Given this list of marker genes CORIN, ICOSLG, SLC34A1, FZD9, CRIPTO, KCNQ3, TSHR, MDGA1, RAMP3, SEMA7A, CD47, CRLF2, SLC46A1, CSF1R, ASTN1, HHLA2, HCN1, FSHR, NCAM1, CCR9, SCNN1G, CCR3, PECAM1, CNTN2, TRGV4, CXCR3, DSCAML1, CD86, SLC1A1 (NCBI Gene Id 6505), PSG5, PDIA4 (protein disulfide isomerase family A member 4), ERMAP, IL1RAP, TRGC1, ELANE, ADAM32, SEMA6D, NLGN4X, IL15RA, CXCL12, AXL, ANTXR1, GHRHR, SFRP1 (NCBI Gene Id 6422), SLC46A2, ISLR2 (immunoglobulin superfamily containing leucine rich repeat 2), ACVRL1, FCN1 (ficolin 1), WIF1, CLEC17A, HRG, CRIPTO3, FOLR3 (NCBI Gene Id 2352), SLAMF6 (NCBI Gene Id 114836), PRND, CD83, CAV3, SCNN1A, IRAK1, L1CAM, KCNE2, CLEC1B, PHB1, CFC1B, AZGP1, ADGRE1, TMIGD1, PDCD1LG2, MRC1, SIGIRR, ITGA8, EPHA4, MUC17 (mucin 17, cell surface associated), ITGB1, ADAM15, SLC9A3, CTSK, IL1RAPL2, AIMP1, ADAM17, UPK1A, CEACAM7, GPC4, ANTXRL, TLR2, MPL, CD207, SLITRK6, ADAM30, CD79B, FCRLA, TNF, NOTCH2, KLRK1, CAPN5 (NCBI Gene Id 7445), CST8, CD248, RTP1 (NCBI Gene Id 132112), BTNL10P (butyrophilin like 10, pseudogene), CD244, ADAM28 (ADAM metallopeptidase domain 28), HILPDA, ADGRA2, ATP1A2, PTPRJ, SERPINA5 (serpin family A member 5), FCGR2C, CD24, HAVCR2, ENTPD6, UNC5C, CAPN2, FZD5, ROBO4, TNFRSF1A, GP2, ITGA1, CD44, ITGA2, IL11RA, CLEC4E, MME, CLEC4A, GFRA4 (NCBI Gene Id 64096), ENG, FCRLB, CD163L1, MBL2, KLRC1, CXCR2, CALR, FZD6, CD14, CD80, TNFRSF4, ICAM1, PACC1 (proton activated chloride channel 1), TREML4, ITGAE, ACVR1B, BTN3A1, IL13RA2, MR1, CD200, IL12RB2, IL4R, TF (transferrin), IL1RL1, HLA-H, PROM1, HAVCR1, P2RX1, HLA-DRB1, CD109, TPBG, NOTCH4, ROBO1, LRFN2, CCR1, ATP5F1A, BTN2A2, RTP2, MYH9, TNFRSF11A, CLEC5A, BTN3A2 (butyrophilin subfamily 3 member A2), FCGR2A, GFRA2, BMP2 (NCBI Gene Id 650), HLA-G, CLDND1, CD63, SULF1, TSPAN33, ENOX2, LAMP3, GP6, CD1C, ANXA5 (annexin A5), PLET1, SCARA5, GFRA3, LCT, MXRA8, IL9R, S100A10, LRRTM1 (NCBI Gene Id 347730), AQP4, VEGFA, FGFR3, EGFL8 (NCBI Gene Id 80864), EGFL7, IL1R2, LMAN2, S1PR1 (NCBI Gene Id 51546), INTU, EMP2, ANTXR2, CLMP, ATP5PO, CEACAM4, CD1E, HBEGF (heparin binding EGF like growth factor), CD8B, TFRC, SPN, LRFN1, LAMP1, F10, IL2RB, CD27, ZPLD1, TRPV2, CXCR4, PRNP, THY1, GPC6, HSP90AA1, FCGR1BP, HM13, FAM234A, SELE, ASIC1, WNT1, CD1B, UMODL1, ITGA11, SLC22A11, WNT5B, ROR1, LRP8, SLC7A11, TRGV9, IZUMO1R, MPZL1, BSN, BTNL9, LAG3, SLAMF1, PTPRK, MAP3K5, CXCR6, PLVAP, TNFRSF10B, CLEC12B, LBP, ADAM7, PSG11, GPRC5B, CYP2W1, ASGR1, PTPRT, AMBP, SLC9A1, ACVR2A, HYAL2, PROCR, ATP5F1B, SLC6A2, KRT4, DMD, GPIHBP1, CD74, TMEM8B, FCRL1, SRPX2 (sushi repeat containing protein X-linked 2), CLEC7A, STRC, TGFA, HSPA5, ALCAM, ITGBL1, CCR8, FZD3, IGSF5 (NCBI Gene Id 54046), TMEM102, LRRC32, LEPR, CLIC4, CD274, IL18R1, CD209, TYROBP, KCNA5, LDLR, INSR, NTRK1, FGA, GRIA1, NEO1, AMELX, TSPAN15, ATP6AP2, CSF3R, FGFBP1, MUC16, ABCG2, CD84, HLA-DPB1, SELL, LY6D, DUOX1, ADAM9, RAET1G, ECE1, SLC2A4, TPO, BMPR2, FURIN, CLEC9A, LTF, ITGA5, IL12RB1, GJD3, ITGAD, ENO1, GRIN2A, TGFBR3, IL17RC, NOTCH1, TREML2, OIT3, IL17A, KLRC3, CXCL9, CD19, LY6G5B, CLEC10A, GPR37, PXDN, SULF2, SLC32A1, OTOA, RAMP1, PPFIA2, CUBN, TMX3, FOLR1, VASN, DPP4, CSPG4, FZD10, ENPEP, CD3G, CASR, RALA, ABCG1, MSLNL, HMGB1, ITGB2, SLAMF7, TEK, CTSB, ADTRP, RS1, IL27, LY6G6D, FOLR2, RTN2, AOC3, MRGPRX1, ROBO2, IL7R, KCNC1, COLEC11, SLC4A3, C3, PSG2, HHIP, SCUBE3, ST14, PROM2, LRPAP1, CEACAM8, KLRB1 (NCBI Gene Id 3820), PHB2, MCAM, SLC39A6, HLA-DMA, ITGB3, ADGRV1, IGF2R, EPO, CTSZ (NCBI Gene Id 1522), ITGA6, LY6G6C, WNT4, LRP4, ADAM29, RC3H2, KISS1R (KISS1 receptor), NDP, LAYN, RTN4RL1, SORL1, CLEC4G, ACKR3, GPRC6A, P2RY12, ADAMTS15, CLEC4M (NCBI Gene Id 10332), IL18RAP, CD8B2 (NCBI Gene Id 927), ERP29, HMMR, TRGV3, IL2RG, CLEC6A, ITGB4, CEACAM6, TECTB, FLT3LG, ADGRG2, FCRL5, IL23R, TLR3, TNFSF4, BMPR1A, FCRL3, GRIN2B, CD6, PDGFB, CD4, KLRD1, GHR, SIRPB1, LRFN5, LIFR, PDGFC, ACE, C17orf99, FCGR3A, HPN, NRDC, ANXA9, MYH10, MS4A2, PICALM, FCGR3B, CD200R1L, CD1D, ADAM10, ADGRA3 (NCBI Gene Id 166647), EPHA2, PKD1, TAS2R16, BTNL3, CDH17, TNFRSF10A, ITGAL, TNS1, ITGAX, ITGA3, NLGN1, GREM1, ADGRF5, MS4A1, CLEC4F, KCNN2, FCER2, LRFN4, PPFIA4, ATP5IF1, BSPH1, SLC7A5, CD36, KCNH2, CCR7, ABCC2, COLEC10, CD34, ADCYAP1R1 (NCBI Gene Id 117), EPHB2, BTN2A3P, LYZL6, PCSK9, HFE, GRIA2 (glutamate ionotropic receptor AMPA type subunit 2), TMC1, FGF10, ABCA1, HSPA2 (heat shock protein family A (Hsp70) member 2), CNTNAP2, SEMA6C, SPTB, TSPAN8, ULBP1, LIPG, GPC2, FGG, TNFRSF10D, SCNN1B, SLAMF8, GPC3, ADAM8, ENPP3, BACE1, MMP16, FCRL4, FUT4, ANK3, ABCA7, IL3RA, ITGA9, KDR, PLXNB3, FCN2, HYAL4, LRP2, ANXA1, TCN2, MICB, TNFRSF18, TGFB1, FZD1, TSPAN14, RTBDN, CD163, WNT6, IL2RA, AQP11, ADIPOQ, SHH, APMAP, LY6G5C, CD99L2, IQGAP2 (NCBI Gene Id 10788), FCRL2, USP14, HSP90AB1, P2RY1, FCER1G, AJAP1, SDC4, CLPTM1, RAET1L, WNT7A, CLEC2D, CHRNB2, CCR10, RSPO2, CD276, CX3CL1, TRPV4 (NCBI Gene Id 8098), PLAUR (NCBI Gene Id 5329), BTNL2, LY75, ENTPD1, KCNB1, PDGFRA, CD40, EPHA5, GPC5, ADAMTS13, BST2, FGF8, NOD2, SPARC, CX3CR1, CD55, ACKR4, CFTR, UMOD, CD22, SORT1 (sortilin 1), MBP, PKD2L1, IL21R, SLC38A1, TMPRSS11F, TSPEAR, CD93, FOLH1, NTSR1, CLEC4C, CLU, FLOT1, IL13, RGMA, FGFR2 (NCBI Gene Id 2263), LMO7, FCGR1A, MICA, TRGV1, CD1A (NCBI Gene Id 909), TRGV2, TGFBR2, BGN, WNT3A, F2R, PKHD1, PDGFA, ITGAV, MSLN, ENO2, SCARB1, CSPG5, CLEC14A, ABCB1, AREG, BTN1A1, CSF2RB, PLXNB2, EGFR, FAP, ENPP1, LPAR1, FAS, STAB2, TYRO3, HLA-E, GPC1, BTN3A3, HLA-B, SDC1, LILRA5, IL1R1, TACR1, CCRL2, LPL, SCUBE2, CHRNA1, CLSTN1, CDH5, RAMP2, CD226, DIP2A, IRAK4, CD200R1, TRPM8, ITGA7, SLIT2, SLC1A3, TNFRSF14, CLEC4D, AGER, IDE, CEACAM5, B4GALT1, IL5RA, CD2, VTCN1, CD5, KRT10, PCSK6, GFRA1, HLA-DPA1, F2, TNN, PVR, IGSF3, ULBP3, VAMP4, HLA-C, CD9, STX4, LRRC8A, HJV, VAMP5, ADAMTS9, CCR2, ADAM20 (ADAM metallopeptidase domain 20), NCR2, TRGV5, PLAT, CPM, SLITRK3 (NCBI Gene Id 22865), CD58, UNC5D, SLC4A4, HTR3B (5-hydroxytryptamine receptor 3B), ART1, MYD88, ANPEP, EPOR, PTGFRN, BTN2A1, ANOS1, CD79A, IL12B, PKD1L3, CA4, DAG1 (NCBI Gene Id 1605), ELSPBP1, ENOX1, CCR4, NPTN, HLA-F, TRPC4, ADAM2 (ADAM metallopeptidase domain 2), CSF2RA, SLC6A3, APP, FCRL6, SARM1, GLRA1, DSG2, GSR, VCAM1, CUZD1, TFPI, TNFRSF10C, HCST, VWDE, SERPINF2, TLN1, SCUBE1, DNAI2, CLCN3, ULBP2, TSPAN32, SIRPA, IL31RA (interleukin 31 receptor A), PLA2R1, SDC3, NECTIN2, NRCAM, TRGV10, HLA-DRA, APOH, TIGIT, LILRB4, MIF, CDH2, SELP, CXCR5, APOA4, EFNA5, NRXN1, PRLR, LRP6, ITGAM, FCER1A (NCBI Gene Id 2205), SRPX (NCBI Gene Id 8406), IL6R, ITGB8, ABCC4, ACKR2, CEACAM3, PSEN1, GABRB3, HSPD1, PLAU, KCNA1, TIRAP, CEACAM20, DCC, RTN4RL2, KLRC2, STRCP1, IGHM, CEACAM21, F3, FCN3, IL17RB, CLSTN2, CXCL10, DCBLD2, SPA17, ACHE, FASLG, CRLF1, SMIM1, NOTCH3, ITGB7, TNFRSF13C, PTPRC, MELTF, CD59, CD69, VAMP3, IL1RL2, MYO18A, SEPTIN2 (septin 2), IL13RA1 (interleukin 13 receptor subunit alpha 1), PDCD1, CD5L, RER1, KLRC4-KLRK1, SLAMF9, B2M, TNFRSF12A, LGALS3, GFRAL, NGFR, KCNH5, CCR5, CD38, PDIA3, H1-1, PLA2G1B, EPPIN, IGSF21, LILRB1, CEACAM1, DCSTAMP, TFR2, CLSTN3, CD40LG, LRRC24, SCN5A (NCBI Gene Id 652341), CD46, CLEC2A, MET, ANGPTL3, CXCR1, EFNB1, ARSB, ALPP, ITGA4, CD8A, ASGR2, HNRNPU (heterogeneous nuclear ribonucleoprotein U), SLC1A4, JAM2, GRIN1, CD28, CDH13, MILR1, BTNL8, AMOT, GP1BA, BMP10, OSMR, ERP44, TREML1, NRROS, SDC2, ADGRG6, SLC3A2, NLGN2, TNFSF18, ADA, SLC6A1, FERMT2, FGB, CD33 (NCBI Gene Id 945), TLR4, TLR8, KCNK2, DUOX2, CD151, NLGN3, CD3E, CACNG4, ABCB11, IL6ST, CHRNA4, C1QBP, FGF22, MOG, ANXA2, P4HB, CRYAB, WNT5A, MST1R, LY9 (NCBI Gene Id 95630), TGFBR1, ADAM21, BCAM, ITGA2B, CR1, AAMP, KLRC4, ITGA10 (NCBI Gene Id 8515), LPAR2, SLC26A9, LRFN3, TNFRSF9, LILRB2, SLC1A2, CCR6, ANO6, ADAMTS7, THBS1, ITGB5, SLC11A2, MFGE8, TRGV8, CTLA4, CACNG2, HLA-A, H2BC1, GLDN (NCBI Gene Id 342035), PLG, EPCAM, CFC1, TNR, ACE2, TREM1, ADRA2B, NT5E, ITGB6, THBD, FZD4, XCR1, FCGR2B, RAET1E, KCNJ3, KCNE1, CNTFR, P2RX7, FCGRT, GHSR, ATP1B2, SFRP4, TRGC2, RTN4R, MSN, ANXA4, IL1RAPL1, COL23A1, CD3D, KIT, HEG1, TMEM123, here is a description of the gene set: species: Homo sapiens The external part of the cell wall and/or plasma membrane. Human Gene Set: GOCC_CELL_SURFACE